Given this list of marker genes OAS2, MAPK9, COMMD3, GBP2, TNIP1, RASA4, PLAC8, SMCHD1, AZI2, SERPINB9, ARHGAP30, IFT52, TMBIM6, COPB1, TMEM39A, DDX52, TMEM184C, IL15RA, PSME2, CCNJ, PSMC6, RAPGEF2, MRPL39, PFDN2, SSH2, WDR91, SF3B2, GBP4, DDX60, N4BP1, REXO4, LILRB4, CHMP4B, IFI30, NOM1, ANAPC7, DPY19L3, RBM28, POMT2, PLIN2 (NCBI Gene Id 123), XAF1, IFI44, NFKBIA, PPA1, FCGR1A, USO1, RPL8, DAXX (NCBI Gene Id 1616), TMCO4, SMCR8, SLAMF8, DNASE1L3, SELENOW, CYBA, CFB (NCBI Gene Id 629), LY75, ICAM1, CENPC, NR1H3, GADD45B, TBCK, LGALS3, EDEM1, AOAH, DENND6A, PML (NCBI Gene Id 5371), GBP5, GRN, NMI, USP5, PPM1K, SLC6A6 (NCBI Gene Id 6533), ZBP1, TDRD7, PSMB4, CXCL9, RPL7L1, ISG15, IFI16, IFIT1, RNF114, SLC15A3, DCLRE1C, PSMB10, PSMB8, RANBP2, PNPT1, CACNB3, NAA20, RNF19B, ARF4, ZNFX1, POLR3C, GZMB, RFC3 (NCBI Gene Id 5983), SHMT2, IRGM (immunity related GTPase M), EEF1E1, IL15, TPST1, EXOC1, RPS18, CSRP1, TMEM199, PSMC5, ZBTB32, PIK3AP1, XRN1, STRIP2, CDC37L1, STX16, RAB22A, TMEM171, PSME1, ATP11A, MSR1, NOD1, LGALS3BP, PDE7B, ACAP2, POLR2G, ETNK1, PSMB9, MSRB1, PARP14, SETDB2, PHF11, RCC2, CARMIL1, EIF2AK2 (NCBI Gene Id 5610), GSDMD, AIF1, KDR, ANXA4, SLAMF9, ATP8B4, TSPO, POGLUT1, VWA5A, MYBBP1A, BBX, MOV10, ZCCHC2, IFIT2, NCL, OCIAD1, COPS7A, TLR9, TGFBI, ASB13, PRR13, KEAP1, LITAF, LIF, TXNDC16 (thioredoxin domain containing 16), SH3BP2, AIDA, LRP8, SNAPC4, ASPRV1, POLR3B, NMRAL1, GFM2, CEP43, MIF, SLC25A22, IRF7, FSCN1, POLR1C, LGALS9, TRIM21 (tripartite motif containing 21), MINDY3, here is a description of the gene set: Human Gene Set: GSE6259_DEC205_POS_DC_VS_BCELL_DN Dendritic cells (DCs) process and present self and foreign antigens to induce tolerance or immunity. In vitro models suggest that induction of immunity is controlled by regulating the presentation of antigen, but little is known about how DCs control antigen presentation in vivo. To examine antigen processing and presentation in vivo we specifically targeted antigens to the two major subsets of DCs using chimeric monoclonal antibodies. Unlike CD8+ DCs that express the cell surface protein CD205, CD8- DCs, which are positive for the 33D1 antigen, are specialized for presentation on MHC class II. This difference in antigen processing is intrinsic to the DC subsets and associated with increased expression of proteins associated with MHC processing. from publication Dudziak D, Kamphorst AO, Heidkamp GF, Buchholz VR, Trumpfheller C, Yamazaki S, Cheong C, Liu K, Lee HW, Park CG, Steinman RM, Nussenzweig MC (PMID 17204652) studied in species Homo sapiens Genes down-regulated in splenic dendritic cells: DEC205+ versus B lymphocytes.